Given this list of marker genes TOGARAM1, MAGEF1, USE1, TENT4B, CAST, ZNF493, UBR3, ZYG11B, TNFRSF13B (NCBI Gene Id 23495), NT5C3A, CBFA2T2, OXR1, C6orf62, CCNT2, GOLM2, SPACA1, ATP9A, ADD3, TRAPPC2, ANGPTL2, TMC6, DANCR, ABCB1, PARP6, ITGB7, TTLL3, FAM110B, IFIT1, SLC35B3, GBP6, CCNL2, KBTBD2, PDP1, DHRS11, LRRC45, GRAMD1A, RFFL, ADCY7, ADAMTS10, RNF139, MED1, MBNL1, TEX264, ZBTB4, RABAC1, OSGIN1, CEBPB, PRKCZ, GPR83 (G protein-coupled receptor 83), SYTL1, ANKRD16, GLIPR2, TUBA4A, FAM168B, LCK, LPAR6, FMNL3, GOLGA5, NMB, SNRK, FAM76B, MOSMO, RAB11FIP2, CCDC62, PUM2, APC, RNF145, NTAQ1, FBXO33, NRBP1, PDE2A, MED15, SIMC1, DGUOK, KCTD18, MS4A6A, FYN, ADI1, ZNF639, E4F1, FOXN2, CDK5, TAF5L, SBF1, FYCO1, RFX7, DHX33, CHD9, DAPP1, SP1, CYP4V2, AATF, CBL, SRPK1, ARHGAP15, CNBD2, FAM241A, NEMF, BAG3, ABR, PIK3C2A, TBC1D8B, MAPK8IP3, HOPX, LTA (lymphotoxin alpha), FNBP4, SNRNP48, UBR5, TPCN1, CLCF1, ZC3H13, TMEM106B, DHX8, TRIB1, EXD2, ASXL2, CDK17 (NCBI Gene Id 5128), PKP4, DDB2, SULF2, DET1, MAT2A, HLCS, PRKCE, ELMO3, MTERF3, TTC7A, CCDC126, SLC49A4, MFAP1, IKBKE, RUFY1, AFG2B, OSTM1, IK, H2AC25, VPS16, SHTN1, STX17, VPS13D, NUDCD3, XPO6, AKAP9, RBL2, GCFC2, BMP2K, TAPT1, NLRC3, PKD1 (NCBI Gene Id 5310), MORC2, RFXANK, DYRK1A, GIMAP5, USP48, TTLL4, ANKHD1, RCAN3, AGER, TRIM26, LAT, KDM7A, ZBTB11, PHC3, TMEM81, ZC3H12A, GNS (glucosamine (N-acetyl)-6-sulfatase), ADNP, LY6E, AKAP8L, GSK3B, ATP1B3, AIRN, WDR44, SPIN1, RDH10, CRTC3, PPP1R3F, IL27RA, TRAPPC10, RHOH, APMAP, EIF3E, OTULINL, ZNF281, PLEKHG2, LMTK2, JADE1, SLC35D2, RWDD3, BIN1, CA2, ESYT2, SNAPC5, BRD8, PARP8, BTG2, DPP4, DGKA, KLF9, ZMYM4, here is a description of the gene set: Human Gene Set: GSE14350_TREG_VS_TEFF_IN_IL2RB_KO_UP Genes up-regulated in comparison of regulatory T cell (Treg) from IL2RB defficient mice versus effector T cells from IL2RB defficient mice. studied in species Homo sapiens Interleukin-2 receptor (IL-2R) signaling is essential for T regulatory (Treg) cell development and homeostasis. Here we show that expression of IL-2Rbeta chains that lack tyrosine residues important for the association of the adaptor Shc and the transcription factor STAT5 in IL-2Rbeta-deficient mice resulted in production of a normal proportion of natural Treg cells that suppressed severe autoimmunity related with deficiency in IL-2 or IL-2R. These mutant IL-2Rbeta chains supported suboptimal and transient STAT5 activation that upregulate the transcription factor Foxp3 to normal amounts in natural, but not induced, Treg cells. Using cells T cell obtained from normal C57BL/6 mice and mice harboring Treg cells with impaired IL-2R signaling, gene expression profiling revealed many targets in peripheral natural Treg cells that were IL-2-dependent and a substantial overlap between the Treg cell IL-2-dependent gene program and the Treg cell transcriptional signature. Collectively, these findings demonstrate that a critical, and perhaps minor, subset of IL-2-dependent targets in Treg cells is indexed to a low IL-2R signaling threshold and that a substantial proportion of the Treg cell gene program is regulated by IL-2. CD4 T effector cells also showed many IL-2R-dependent gene and these also overlapped in a distintive manner with the IL-2-dependent genes of Treg cells and the Treg gene signature. from publication Yu A, Zhu L, Altman NH, Malek TR (PMID 19185518)